Given this list of marker genes PXDN, PEDS1-UBE2V1, ADAR, GYS1, PODXL, GALNT1, ANPEP, MIR29C, ATP6V1F, TNFRSF10B, PRPF40A, MIR124-2, CBFB, POLD2, MIR126, RHEB, POM121 (POM121 transmembrane nucleoporin), DNAJB1, FMNL2, AP2A1, ACAA2, GFPT1 (glutamine--fructose-6-phosphate transaminase 1), HMOX1, MIR23A, PICALM, SIGMAR1, E2F3, P4HA2 (NCBI Gene Id 8974), ELOVL5, NF2, MAP3K8, CHMP2A, MAGT1, MIR26A1, HES1, MIR30A, PDLIM7, TRAM1, NEDD4, MIR30E (microRNA 30e, NCBI Gene Id 407034), PNP, CPNE8, AXL, MIR34A, CSDE1, SRSF9, TPM1, SH3BGRL3, THBS1, SLC4A10, ARF4, LAMTOR5, SYNE2, SEC23A, SH3BP4 (SH3 domain binding protein 4), MIRLET7A1, MTPN, COMMD9, TPM3, RARS1, LAMC1, BET1, TMEM43, MIR196A1, UBE2J1, MIR133A1, SLC38A1, ATP6V1C1, PPP1R7, ATP2A2, MOV10, VCAM1, TXNRD1, TUBA1A, MIR375, PTMA, NCL, RAI14, AP3D1, POGLUT3, MIRLET7A2 (microRNA let-7a-2), TMED10, MPZL1, MIR124-3, MIR30D, POLR2C, RTN4, SPCS3, MET, GAS2L1, ATRX, DHX40, ANP32B, SMAD1, HSD17B12, MIR196B, FBXW11, ADIPOR2, MIR103A1, MIR16-1, HOXA7, MIR1-1, MIR370, PISD, MIR155, NRP1, SDCBP, SRPRB, ARFIP1, MIR23B, ANXA2, MIR26A2, MIR21, HMGA1, AKAP8, CTDSP1 (NCBI Gene Id 58190), CIAO2A, HNRNPM, MIR30C1, MIR30B, DHX57, MRC2, PKM, SLC12A2, MIRLET7B (microRNA let-7b), SPTLC1, FNDC3A, FGF2, TBCA, MIR16-2, PWP1, VEZT, TMEM59 (transmembrane protein 59), YWHAQ, ATP6V0E1, CUL4B, ARCN1, RAB34, FNDC3B, MIR20A (NCBI Gene Id 406982), IDH1, GALNT7, TMED7 (NCBI Gene Id 51014), TGFBR2, PDCD4, MIR133A2, MIR199A1, MIR199A2, SLC38A2, GNAI2, MIR133B, TMED2, GOLGA7, MRPS33, MRPL20, MIR30C2, MIR196A2, here is a description of the gene set: miR-targeted genes in squamous cell species: Homo sapiens Human Gene Set: WP_MIRTARGETED_GENES_IN_SQUAMOUS_CELL